Given this list of marker genes ZYX (NCBI Gene Id 7791), ILKAP, PPP1R14B, AURKA, PXN, PPP1R12A, PARP1, CDC42, TACC3, PARVB, CDC37, ACTN1, ARHGEF6, ILK, AKT1, RHOG, RUVBL2, RUVBL1, PPP1R14C, LIMS1, GSK3B, HSP90AA1, JUN, IQGAP1 (NCBI Gene Id 8826), GIT2, PPP1R14A, TNS1, NCK2, XPO1, LIMS2, CCND1, NACA, CREB1, CKAP5, ELMO2, RAC1, ARHGEF7, CTNNB1 (catenin beta 1), SNAI1, DIAPH1, ZEB1, PARVA, PARVG, RICTOR, MYL9, here is a description of the gene set: Integrin-linked kinase signaling Human Gene Set: PID_ILK_PATHWAY from publication Schaefer CF, Anthony K, Krupa S, Buchoff J, Day M, Hannay T, Buetow KH (PMID 18832364) species: Homo sapiens